The following is a description of a gene set: Neighborhood of ORC1L studied in species Homo sapiens Neighborhood of ORC1L origin recognition complex, subunit 1-like (yeast) in the MORF expression compendium Human Gene Set: MORF_ORC1L, and this is the list of marker genes: NDST1, PAIP2B, KAT7, PITPNM1, XRCC2, HMGB1, MGAT1, ZBED1, LSM12, PKMYT1, TCOF1, COPS2, GPR35 (NCBI Gene Id 2859), TAF1, PTPN9, ARIH2, TNK2, TUB, ORC1, GPR161, PCBP3, IGSF9B, PAX8, DRG2, RFC1, NUDT3, GSK3A, ZFPL1, GTF2F1, CASP2, PRPF8, IGHMBP2, CNTN1, CELA2A, ARPC3, TAFAZZIN, DNAJC8 (DnaJ heat shock protein family (Hsp40) member C8), PSD4, SIK3, POLR2A, B4GALT3, CAMK2B (NCBI Gene Id 816), MVK (mevalonate kinase), CNP, SUMO4, FCHO1, ZNF337, CRYBA4, PNMT, PLIN3, ARSL, IRF2BP1, PTGER3, ANKRD12, HNRNPL, TXLNA, RPA2, IKBKG, PRKCSH, PSMA1, TOMM34, ADAM15, RAP1GAP2 (RAP1 GTPase activating protein 2), M6PR, ENTREP3, SLC12A4, GHITM, TSPO2, GRK6